The following is a description of a gene set: Human Gene Set: GOBP_NEURON_FATE_SPECIFICATION species: Homo sapiens The process in which a cell becomes capable of differentiating autonomously into a neuron in an environment that is neutral with respect to the developmental pathway. Upon specification, the cell fate can be reversed., and this is the list of marker genes: FEV, GLI2, ASCL1, POU4F1, HOXD10, FKBP8, MNX1, ISL2, HOXC10, DMRTA2, SMAD4, FOXA1, GLI3, SOX1, SIX1, POU3F2, EHMT2, MIR125A, LMO4, NTRK3, TLX3, ISL1, DLL1, GSX2, SUFU, EYA1, DBX1, LHX3, NFIA, NKX2-2, DMRT3, ATOH1, OLIG3 (NCBI Gene Id 167826), SOX9, MYT1L, ESRP1, NFIB